Given this list of marker genes GSTM5 (NCBI Gene Id 82154), CYP2C19, ACOT2, CYP7A1, ACTG1, ANXA5, LGALS1, LGALSL, ACOT1, CYP2B6, GADD45B, FGL1, CYP2C18, VNN1, ANTXR2, HMOX1, CYP2A6, GSTM1, ASNS, SLCO1A2, CES2, GSTA2, RETSAT (retinol saturase), ENTPD5, here is a description of the gene set: from publication Weng Y, DiRusso CC, Reilly AA, Black PN, Ding X (PMID 16006652) species: Mus musculus Genes up-regulated in liver from mice with liver specific knockout of POR vs mice with reduced expression of POR in all tissues. Human Gene Set: WENG_POR_DOSAGE NADPH-cytochrome P450 reductase (CPR) is an essential component for the function of many enzymes, including microsomal cytochrome P450 (P450) monooxygenases and heme oxygenases. In liver-Cpr-null (with liver-specific Cpr deletion) and Cpr-low (with reduced CPR expression in all organs examined) mouse models, a reduced serum cholesterol level and an induction of hepatic P450s were observed, whereas hepatomegaly and fatty liver were only observed in the liver-Cpr-null model. Our goal was to identify hepatic gene expression changes related to these phenotypes. Cpr-lox mice (with a floxed Cpr gene and normal CPR expression) were used as the control. Through microarray analysis, we identified many genes that were differentially expressed among the three groups of mice. We also recognized the 12 gene ontology terms that contained the most significantly changed gene expression in at least one of the two mouse models. We further uncovered potential mechanisms, such as an increased activation of constitutive androstane receptor and a decreased activation of peroxisomal proliferator-activated receptor-alpha by precursors of cholesterol biosynthesis, that underlie common changes (e.g. induction of multiple P450s and suppression of genes for fatty acid metabolism) in response to CPR loss in the two mouse models. Additionally, we observed model-specific gene expression changes, such as the induction of a fatty-acid translocase (Cd36 antigen) and the suppression of carnitine O-palmitoyltransferase 1 (Cpt1a) and acyl-CoA synthetase long chain family member 1 (Acsl1), that are potentially responsible for the severe hepatic lipidosis and an altered fatty acid profile observed in liver-Cpr-null mice.